The following is a description of a gene set: Cutaneous amyloidosis Human Gene Set: HP_CUTANEOUS_AMYLOIDOSIS The presence of amyloid deposition in the superficial dermis. studied in species Homo sapiens, and this is the list of marker genes: OSMR, B2M, NLRP1, RET, POLA1, IL31RA, APOA1